The following is a description of a gene set: Human Gene Set: HP_ABDOMINAL_COLIC A type of abdominal pain that comes and goes in waves, most often starting and ending suddenly and being of severe intensity. species: Homo sapiens Abdominal colic, and this is the list of marker genes: APRT, ALAD, ABCB4, SI, DGAT1